The following is a description of a gene set: Human Gene Set: HP_HIP_SUBLUXATION species: Homo sapiens Hip subluxation A partial dislocation of the hip joint, whereby the head of the femur is partially displaced from the socket., and this is the list of marker genes: GET4 (guided entry of tail-anchored proteins factor 4), LMNB2, B3GALT6, AFF4, NFIX, BICRA, KIF22, GNPTAB, DHCR7, GNB2, PLOD1, DDR2, COL6A3, THOC2 (NCBI Gene Id 57187), CTCF, SLC35A2, FAT4, IFIH1, EIF2AK3, EIF4A3, NEPRO, TONSL, OSTM1 (NCBI Gene Id 28962), ZNF407, TRAPPC12 (trafficking protein particle complex subunit 12)